Given this list of marker genes CCL11, OAS1, CXCL10 (NCBI Gene Id 3627), IFI27, IFI35, VCAM1, MT2A, WARS1, IFIT3, IRF7, APOL1, CCL2, CXCL9, GBP4, IFIT1, GBP2 (NCBI Gene Id 2634), EPSTI1, CD74, STAT1, MX2, HAPLN3, IFIT2, TNFSF10, IFITM1, CMPK2, ISG20, UBE2L6, IFI44L, PSMB9, PLSCR1, PARP14, XAF1, TAP1, RIGI (NCBI Gene Id 23586), GBP1, SOD2, ISG15, LAP3, RSAD2, CXCL11, IFI6, OASL, PLAAT4, BST2, TNFSF13B, CTSS, MX1, MMP11, IDO1, OAS3, here is a description of the gene set: In this study, an extensive analysis was conducted to define meta-programs (MPs) capturing intra-tumor heterogeneity across a spectrum of tumor types. The approach utilized non-negative matrix factorization (NMF) to analyze each cell type separately within individual tumor samples. This involved the analysis of malignant cells, macrophages, fibroblasts, endothelial cells, epithelial cells, T-cells, and B-cells. NMF was executed with varying parameter values (K=4, 5, 6, 7, 8, 9), thereby generating 39 programs for each cell type per sample. Each NMF program was summarized by the top genes based on NMF coefficients.\nRobust MPs were then delineated for each cell type using a set of stringent criteria, including recurrence within the same tumor, similarity to programs in other tumors, and non-redundancy within a tumor. Subsequently, these robust NMF programs were clustered (per cell type) based on Jaccard similarity, leading to the identification of MPs associated with each cell type.\nTo enhance the quality of the MPs, a refinement steps were undertaken, involving the removal of MPs suspected of reflecting low-quality data (with an overrepresentation of ribosomal proteins or mitochondrial-encoded genes), single-study inclusion, or similarity to miss-annotated cell types. Human Gene Set: GAVISH_3CA_METAPROGRAM_FIBROBLASTS_INTERFERON from publication Gavish A, Tyler M, Greenwald AC, Hoefflin R, Simkin D, Tschernichovsky R, Galili Darnell N, Somech E, Barbolin C, Antman T, Kovarsky D, Barrett T, Gonzalez Castro LN, Halder D, Chanoch-Myers R, Laffy J, Mints M, Wider A, Tal R, Spitzer A, Hara T, Raitses-Gurevich M, Stossel C, Golan T, Tirosh A, Suvà ML, Puram SV, Tirosh I (PMID 37258682) species: Homo sapiens Genes upregulated in subsets of cells of a given type within various tumors